The following is a description of a gene set: species: Mus musculus The proteolytic removal of a signal peptide from a protein during or after transport to a specific location in the cell. Mouse Gene Set: GOBP_SIGNAL_PEPTIDE_PROCESSING, and this is the list of marker genes: Spcs2, Sec11a, Pcsk5, Parl, H13, Sppl3, Immp1l, Immp2l, Furin, Spcs3, Spcs1, Arxes2, Cln5, Arxes1 (NCBI Gene Id 76219), Sec11c